Given this list of marker genes RUNX1, SOCS6, LAX1, HMGB1, RASSF5, PTPN11, TYRO3, PARP3, JAK3, UFL1, LRRC32, VSIG4, SCGB1A1, AXL, PRNP, XCL1, DUSP22, MNDA, LGALS9C, CD69, CRTAM, ZC3H12A, TMEM131L, TNFAIP8L2, MIR181C, GLMN, GNRH1, LILRB1 (leukocyte immunoglobulin like receptor B1), IL4I1, ATM, PRKAR1A, PELI1 (NCBI Gene Id 57334), MIR27A, TNFSF18, RAG2, CD74, INPP5D, IL20RB, SMAD7, BTLA, CEBPB, RC3H2, ZC3H8, MICA, ARG1, SOX11, TWSG1, FCGR2B, IL10, LILRB4, TNFRSF14 (NCBI Gene Id 93208), SOCS5, CLEC12A, LGALS1, LGALS9, BANK1, PTPN6, MIR30B, CTLA4, NDFIP1, INHBA, TBC1D10C, CD80, PIBF1, BCL6, IDO1, DTX1, ANXA1, CBFB, CR1, FBXO7, PGLYRP1, FGL1, IFNL1, DLG1, PLA2G2D, HAVCR2, LAPTM5, CD300A, FGL2, FGR (FGR proto-oncogene, Src family tyrosine kinase), RUNX3, PAWR, TNFAIP3 (NCBI Gene Id 7128), ADORA2A (adenosine A2a receptor), CD86, SAMSN1, LAG3, PTPN2, GAL, TYROBP, SPN, CLEC4G, CBLB, MIR185, ARG2, SHH, MDK, INHA, GPNMB, IFNA2 (NCBI Gene Id 8005), MAD1L1, SDC4, PRDX2 (peroxiredoxin 2), TBX21, STAT5A, SFRP1, SCRIB, HLA-G, BTK, PKN1, CSK, TNFRSF13B, DAPL1, ID2, PDCD1 (programmed cell death 1), ITCH, FOXJ1, IL4R, HLA-DRB1, LYN, FOXP3, DLG5, TARM1, TNFRSF21, MIR21, IL2RA, HLX, SOCS1, TIGIT, BTN2A2, PDCD1LG2 (NCBI Gene Id 80380), PLA2G2F, PLA2G5 (NCBI Gene Id 5322), HFE, NRARP, LST1, CLNK, ERBB2, IFNB1, RHBDD3, TSPAN32, BMP4, MERTK, CD274, TGFB1, RIPOR2, DUSP3, SLC4A2, LILRB2, LGALS3, ILDR2, IL2, HMGB3, CTSG, VSIR, PLA2G2A, LOXL3, CASP3, GLI3, SFTPD, LGALS9B, RC3H1, HLA-E, PGLYRP3 (peptidoglycan recognition protein 3), ASCL2, CDKN2A (cyclin dependent kinase inhibitor 2A), PTPN22, IRF1, TNFSF4, MARCHF7, PGLYRP2, PAG1, ZBTB7B, VTCN1, CD37 (NCBI Gene Id 951), IHH, here is a description of the gene set: Any process that stops, prevents, or reduces the frequency, rate or extent of lymphocyte activation. Human Gene Set: GOBP_NEGATIVE_REGULATION_OF_LYMPHOCYTE_ACTIVATION studied in species Homo sapiens